The following is a description of a gene set: We explored whether the five previously reported molecular subtypes in breast cancer show a preference for organ-specific relapse and searched for molecular pathways involved. The intrinsic gene list describing the subtypes was used to classify 344 primary breast tumors of lymph node-negative patients. Fisher exact tests were used to determine the association between a tumor subtype and a particular site of distant relapse in these patients who only received local treatment. Modulated genes and pathways were identified in the various groups using Significance Analysis of Microarrays and Global Testing. Bone relapse patients were most abundant in the luminal subtypes but were found less than expected in the basal subtype. The reverse was true for lung and brain relapse patients with the remark that absence of lung relapse was luminal A specific. Finally, a pleura relapse, although rare, was found almost exclusively in both luminal subtypes. Many differentially expressed genes were identified, of which several were in common in a subtype and the site to which the subtype preferentially relapsed. WNT signaling was up-regulated in the basal subtype and in brain-specific relapse, and down-modulated in the luminal B subtype and in bone-specific relapse. Focal adhesion was found up-regulated in the luminal A subtype but down-regulated in lung relapse. The five major molecular subtypes in breast cancer are evidently different with regard to their ability to metastasize to distant organ(s), and share biological features and pathways with their preferred distant metastatic site. Genes up-regulated in the luminal B subtype of breast cancer. studied in species Homo sapiens from publication Smid M, Wang Y, Zhang Y, Sieuwerts AM, Yu J, Klijn JG, Foekens JA, Martens JW (PMID 18451135) Human Gene Set: SMID_BREAST_CANCER_LUMINAL_B_UP, and this is the list of marker genes: FAM234B, ASCL1, MSMB, ZNF652, MYT1, AMIGO2, SSTR2 (somatostatin receptor 2), SLC6A4, WFDC2, TMEM101, CYP2A6, GUSBP3, ACOX2, DIO1, NAIP, MLPH, HPN, GUSBP14, TNNT1, TFF3, CHN2, PTPRT (protein tyrosine phosphatase receptor type T), MAGI2, NAT1, TPPP3 (NCBI Gene Id 51673), CEACAM5 (NCBI Gene Id 1048), NKAIN1, EPOR, RAB26, CACNG4, SPINK4, ABAT, TRPA1, EVL, SLC19A2, ZDHHC11, NOVA1, YBX2, TFF1, CA12, SLC8A2, HDAC11, GDF15, EEF1A2, REPS2, IL24 (NCBI Gene Id 11009, interleukin 24), BAIAP3, PLEKHF2, INSM1, QDPR, GLS2, SERPINA5, DACH1, ARMT1, GTF2H2C, TRIM9, RAB11FIP1, RABEP1, GFRA1, RSF1, ALG8, CAMK2B, CYP2B7P, SCCPDH, FBP1, AGL, ABCC8, ABCA3, FGFR2, GLRB, METRN, SLC39A6, DENND1B, SCUBE2, CYP2B6, NELL2, IFT122, KRT18, TBC1D9, RETREG1, CGA, GATA3, GSTZ1, SERPINA6, ISYNA1, DCAF10, CRABP2, SYT1, NHERF1 (NCBI Gene Id 9368), C17orf75, TOX3, KCNE4, IL6ST, LDLRAD4, CRIP1, GSTM3, DNALI1, SORD, PCSK6, DNAJC1, GPR162, PTGES, UGCG, STK32B, RHBDL1, KIF5C, SERPINA3, ANXA9, RASSF1, PYCR3, MCCC2, TTC12, PIERCE1, CACNA2D2, TBC1D30, KDM4B, GNG13, AGR2, NPIPB3 (NCBI Gene Id 23117), ESR1, CACNA1D, CCND1, B9D1, MAPT, SREBF1 (sterol regulatory element binding transcription factor 1), FLRT3, CELSR1, SPAG16, MRPS30, SLC27A2, SEMA3B, SYT17, G6PC3, KCTD3, NUDT6, CHGA, PVALB, SLC1A1, ERBB4, ACADSB (NCBI Gene Id 654185), DNAI7, SIAH2, BMPR1B, ARNT2, GREB1, RET, DNAJC12, PIEZO2, RDH16, PCLO, GP2 (glycoprotein 2), NPY1R, TNNI3, CELSR3, KCNJ3, TEDC2, LINC01503, HEXIM2-AS1, TESMIN, STC1, ENPP1, GRIA2, AGTR1, CCDC106, WWP1, TJP3, SYBU, CLSTN2, PPP1R3C, SERPINI1